Given this list of marker genes Atp8b1, Atp8a1, Atp11c, Atp11a, Atp8a2, here is a description of the gene set: Catalysis of the movement of phosphatidylserine from the exoplasmic to the cytosolic leaflet of a membrane, using energy from the hydrolysis of ATP. species: Mus musculus Mouse Gene Set: GOMF_PHOSPHATIDYLSERINE_FLIPPASE_ACTIVITY